The following is a description of a gene set: Human Gene Set: GOBP_MITOCHONDRIAL_CALCIUM_ION_TRANSMEMBRANE_TRANSPORT The process in which a calcium ion (Ca2+) is transported across a mitochondrial membrane, into or out of the mitochondrion. studied in species Homo sapiens, and this is the list of marker genes: AFG3L2, SLC8B1, VDAC1, MICU3, MICU1, SLC8A3, ITPR1, MAIP1, LETM1, PMPCB, SLC25A23, MICU2, SPG7, UCP2, GHITM, SELENON, PSEN2, HSPA9, SMDT1, MCUR1, BHLHA15, LETM2, MCU, MCUB